The following is a description of a gene set: Genes up-regulated in comparison of monocytes treated with 5000 ng/ml LPS (TLR4 agonist) versus monocytes treated with anti-TREM1. Human Gene Set: GSE9988_LPS_VS_LPS_AND_ANTI_TREM1_MONOCYTE_UP TREM-1 is an orphan immunoreceptor expressed on monocytes, macrophages, and neutrophils. TREM-1 associates with and signals via the adapter protein DAP12/TYROBP, which contains an immunoreceptor tyrosine-based activation motif (ITAM). TREM-1 activation by receptor cross-linking is pro-inflammatory, and can amplify cellular responses to Toll-like receptor (TLR) ligands such as bacterial lipopolysaccharide (LPS). To investigate the cellular consequences of TREM-1 activation, we have characterized global gene expression changes in human monocytes in response to TREM-1 cross-linking in comparison to and combined with LPS. Both TREM-1 activation and LPS up-regulate chemokines, cytokines, matrix metalloproteases, and PTGS/COX2, consistent with a core inflammatory response. However, other immunomodulatory factors are selectively induced, including SPP1 and CSF1 (i.e., M-CSF) by TREM-1 activation and IL-23 and CSF3 (i.e., G-CSF) by LPS. Additionally, cross-talk between TREM-1 activation and LPS occurs on multiple levels. While synergy in GM-CSF protein production is reflected in commensurate mRNA abundance, comparable synergy in IL-1b protein production is not. TREM-1 activation also attenuates the induction of some LPS target genes, including those that encode IL-12 cytokine family subunits. Whereas positive TREM-1 outputs are abolished by the PI3K inhibitor wortmannin, this attenuation is largely PI3K-independent. These experiments provide a detailed analysis of the cellular consequences of TREM-1 activation, and highlight some of the complexity in signal integration between ITAM- and TLR-mediated signaling. from publication Dower K, Ellis DK, Saraf K, Jelinsky SA, Lin LL (PMID 18292579) studied in species Homo sapiens, and this is the list of marker genes: RASSF5, IRF1, PDE6H, NFE2L2, RAP2C, MIR3945HG, SKP1, PLSCR1, PARP10, ACSL1, SLC25A28, SDC4, CHST2, CTNND1, TNFRSF9 (NCBI Gene Id 3604), UGP2, BIRC3, SGPL1, STK17B, IL4I1, TLR8, HNRNPR, NFE2L3 (NFE2 like bZIP transcription factor 3), ADA, PPM1K, RAP1A (NCBI Gene Id 5906), PTEN (phosphatase and tensin homolog), ZNF217, IFIH1, IL23A, BLNK, RAC1, TGFBR2, SRPRA, ANP32A, EHD1, MYO1F, TMPO-AS1, FJX1, PHAX, FOXN2, CLIC4, EPM2AIP1, MYPOP, KCND3, TLR7, STK38, KCNJ2-AS1, TBC1D2B, EYA3, ARID1A, C1orf122, HNRNPH2, TIFA, ATF6, RBM22, SIX5, DNAJB6, CREBL2, IKZF1, ARCN1, SOCS3, PTPRJ, CDC42EP2, RUBCNL, KDM1A, NFKBIZ, NIN, GTF3C6, TRIM49, IKBKE, PLAC8, PIK3R5, CYRIA, PKN2, NDUFV2 (NCBI Gene Id 4729), FPR2, SLC2A6, NBR1, ADAR, MARCKS, VASP, RIN2, ARRB1, KCNJ2, ORAI1, PIK3CD, KLF7, ACOD1 (NCBI Gene Id 730803), TNFAIP2, TNIP1, ZNF436, IL12B, LAIR1, TNFAIP3, CCSER2, CCL1, ARHGAP31, CCM2, PLEKHF2, OASL (2'-5'-oligoadenylate synthetase like), SMG9, TMED7, PFKFB3, VAV1, SAMSN1, SNX18, CWC27, TRIM8, ATP6AP1, ANKRD33B, GCH1, PIK3AP1, QKI, TP53INP1, RPS27A, HCAR3, TOR1B, TAB2, EFNA1, OSR2, GRB2, FFAR2 (free fatty acid receptor 2), PIGV (NCBI Gene Id 55650), NCOA4, CCL23, GNG2 (NCBI Gene Id 54331), ASCC1, EPB41L3, MTF1, BID, LCOR, RND1, MAST3, PNRC1, CD40, MAP3K8, DNAJA1 (DnaJ heat shock protein family (Hsp40) member A1), TNFSF13B, BCOR, ITGB8, BCL9L, SUGT1P1, HDGF, PAXIP1-DT, GPR132, SLC30A7, SINHCAF, XRCC5, APELA, CYBB, CHST12, ACOX1, NADK2, PSMA6, LYSMD2, OAZ2, IER5, TNFRSF10B, RAB13, WNT5A, MYL12A, TLR4, PTAFR, FSCN1, SYNPO2, ARMCX2, TAOK3 (NCBI Gene Id 51347), ATXN7L1, LACC1, LRG1, MARCKSL1, SMCO4, SLA (NCBI Gene Id 6503), UBE2W, RNF19B, SERP1, GTF2F2, C1QTNF1, IL10RA, THBS1, CXCL1, PSMA4, MAD2L2, RNF144B, FAM89B, SCO2, PLAGL2, BIRC2, ACVR2A, YIPF1, RAB11A, GAPT, PDE4B, SMPDL3A, DAPP1, DCP2, HCK